The following is a description of a gene set: Mouse Gene Set: WP_HOMOLOGOUS_RECOMBINATION Homologous recombination studied in species Mus musculus, and this is the list of marker genes: Pold1, Atm, Pold3, Brca2, Rpa1, Nbn, Mre11a, Pold2, Rad52, Rad50, Rad54b, Pold4 (NCBI Gene Id 69745)